The following is a description of a gene set: studied in species Homo sapiens The biological process whose specific outcome is the progression of a metanephric mesenchyme from an initial condition to its mature state. This process begins with the formation of metanephric mesenchyme and ends with the mature structure. Metanephric mesenchyme is the tissue made up of loosely connected mesenchymal cells in the metanephros. Human Gene Set: GOBP_METANEPHRIC_MESENCHYME_DEVELOPMENT, and this is the list of marker genes: SIX4, PAX2, MYC, PKD2, WT1, SHH, WNT4, TCF21, BASP1 (brain abundant membrane attached signal protein 1), STAT1, SIX1, SMAD4, BMP7, OSR1